Given this list of marker genes TMEM38B, SLC34A1, NPR2, CLDN16, SLC34A3, here is a description of the gene set: species: Homo sapiens Human Gene Set: HP_ABNORMAL_CIRCULATING_BETA_C_TERMINAL_TELOPEPTIDE_CONCENTRATION A deviation from the normal concentration of beta-C-terminal telopeptide of type I collagen in the blood circulation, a marker of the rate of bone turnover. Abnormal circulating beta-C-terminal telopeptide concentration